Given this list of marker genes C9orf72, SPG11, ATP13A2, MTHFR, PRPH, PLP1, ATP5F1A, SP110, PON1, HMBS, PI4KA, MTRFR, GJA1, SPG21, ASAH1, NF1, VCP, RNASEH2C, DCTN1, SDHD (succinate dehydrogenase complex subunit D), PON2, PPARGC1A, SPG7, MAG, SRPX2, AIMP1, NEFH (neurofilament heavy chain), ADGRG1, NEK1, CYP27A1, SOX10, ARG1, EDNRB, UBQLN2, SPART, CLTC, ANG, IDUA, ADAR, GAMT, GALC, WDR45, GFAP, GLT8D1 (glycosyltransferase 8 domain containing 1), TNFRSF11A, SQSTM1, SOD1, OPA3, GJC2, MICOS13 (NCBI Gene Id 125988), SAMHD1, IFIH1, SDHA, TREX1, PRPS1, FUS, TRMT10A, GLE1, ALDH3A2, SLC19A3, ANXA11, PEX16, RNU7-1, FAR1 (fatty acyl-CoA reductase 1), HNRNPA1, PRUNE1 (NCBI Gene Id 91961), GOT2, PON3, PFN1, LSM11, OPTN, PNP, GBA1, AFG3L2 (AFG3 like matrix AAA peptidase subunit 2), TTR, POLG, COASY, CHMP2B, VAPB, DAO, TREM2, SDHB, ATXN2, ABCD1, ERBB4, SELENOI, BCOR, CFAP410, ATP6AP2, SLC25A15, FA2H, TAF15, SLC30A10, TTC19, MATR3, CCDC88C, BTD, TBCE, SDHAF1, RNASEH2A, POLR3GL, UNC13A, RNASEH2B, FIG4, MED13L, CCNF, AP5Z1, PPP1R15B, GJB1, TARDBP, CHCHD10, TBK1, CPT1C, MTPAP (mitochondrial poly(A) polymerase), here is a description of the gene set: studied in species Homo sapiens Weakness or partial paralysis in the lower limbs. Human Gene Set: HP_PARAPARESIS Paraparesis